The following is a description of a gene set: Rieger anomaly A congenital malformation of the anterior segment characterized by iridicorneal malformation, glaucoma, iris stroma hypoplasia, posterior embryotoxon, and corneal opacities. Human Gene Set: HP_RIEGER_ANOMALY species: Homo sapiens, and this is the list of marker genes: LETM1 (NCBI Gene Id 3954), LAMB2, FGFRL1, FOXC1, NSD2, CPLX1, IGF1R, CTBP1, PIK3R1, PITX2, PAX6, ADAMTSL1